Given this list of marker genes GOLGA2, PURA, ACTL6B, KCNQ2, TGFB1, ALG2, CARS1, ISCA1, PIGP, SPTBN1, AARS1, PIGS, PNPT1, RNASEH2C, PPIL1, AHDC1, COG5, IFIH1, NEUROD2, TRAPPC2L, SLC12A5, AHCY, GTF2H5, IDH1, CNOT3, ZC4H2, CACNA1I, SLC16A2, ZNF148, PPP3CA, SCN1B, TRMT5, TBC1D24, KCNN2, DCX, GLS, TRIM8 (tripartite motif containing 8), TRRAP, STXBP1, RERE, SLC6A1, NMNAT1, ALG11, PLAA, FLCN, FAR1, CLTC, HNRNPU, TXN2, SLC13A5, SLC6A8, COPB2, SYT1, UGDH, ATP9A, WARS2, POLR2A, GFM1, CREBBP (NCBI Gene Id 1387), KMT2E, MLYCD, LIPT1, ADAT3, ADAMTSL1, LMX1B, RBM8A (RNA binding motif protein 8A), CDKL5, DHFR, ALG13, KIF5A, CLTCL1, CASK, NRROS, NEDD4L, PPP1R15B, SCN1A, EIF2AK2, NIPBL, SLC2A1, GEMIN4, PIGN, ZNF335, SIN3A, SMPD1, TMEM63A, NUP188, IER3IP1, ARF1, PGAP1, CLCN7, ZNF526, SLC35A2, DDX6, KCNC2, ACY1, ARX, LIPT2, ALG9, PPP2R1A, SIK1, KIDINS220, MORC2, TIMM22, KCNT1, EXOC8, PIBF1, FRMPD4, UBA5, ERCC6, HACE1, FOXG1, CTNNB1, HMBS, SCO2, ALG14, BCS1L, NTRK2, NGLY1, C18orf32, FBXL4, ELOVL4, RAB3GAP1, ZFX, GRIK2, DOHH, PIGQ, MTRR, PMM2, NR2F1, COG3, PIGU, CUL3, PNKP, UFC1, TNPO2, PPP2CA, AFG2A, ZMIZ1, STAMBP, RHOBTB2, MAN2B1, ADARB1, YME1L1, MMUT, ALDH6A1, FZR1, PSAT1, NADK2, NAE1, PLCB1, SLC32A1, DNM1L, WWOX, PHGDH, RNF13, COG7, SLC1A4, GATAD2B, HNRNPC, KDM1A, NACC1, MDH2, PHACTR1 (NCBI Gene Id 81705), HIKESHI, POU3F3, SLC19A1, NUP133, CDK19, VPS11, RNU4-2, DHX30, TKFC, KCNA1, FOXRED1, GRIN1, POLR3B, SLC1A2, ASNS, GNAO1, GABRG2, EARS2, HCFC1, H4C5, PRMT7, ITPA, RFX7, PAK1 (p21 (RAC1) activated kinase 1), ASXL1, FCSK, SMG9, ARNT2, TMEM106B, EP300, TNR, MRPS22, DMXL2, TMEM147, POGZ, UPB1, TMEM163, ARID1B, NRCAM (neuronal cell adhesion molecule), WARS1, GLYCTK, EXOSC2, SATB2, CDC40, FBXO28, GMNN, SLC35B2, VPS33A, CLCN3 (chloride voltage-gated channel 3), MTHFS, INTS11, ATP1A3, TPR, SEPSECS, IREB2, PKDCC, MED17, PIGV, FOCAD, KCNH5 (NCBI Gene Id 27133), CLP1, AP3D1, YY1, SLC25A22, DPM1, EZH2 (NCBI Gene Id 392834), ALDH7A1, NARS1, MADD, FRMD5, PRPS1, UBE3A, RNU7-1, PEX7, CLCN4, COX7B, GRM7, CRELD1 (cysteine rich with EGF like domains 1), FANCL, DHX37, HS2ST1, TAF13, ALDH5A1, AIFM1, ASH1L, FDXR, YRDC, PLPBP, TAF2, TRMT10A, U2AF2, RAB11B, SCN2A, CLPB, SETD1A, CHAMP1, FOXP1, ALG12, TRNT1, MAPK8IP3, TMEM240, GNB2, TBCE, OCA2 (NCBI Gene Id 4948), BRAT1, CYB5A, MPV17, EXOSC1, PIGA, FANCB, CYB5R3 (cytochrome b5 reductase 3), PRUNE1, NCDN, GNB1, D2HGDH, BMP4, RAP1GDS1, RMND1, GET4, SHANK3 (NCBI Gene Id 85358), SLC25A1, ATP6AP2, here is a description of the gene set: Delayed myelination. Human Gene Set: HP_DELAYED_MYELINATION studied in species Homo sapiens Delayed myelination